The following is a description of a gene set: Hyperphenylalaninemia Human Gene Set: HP_HYPERPHENYLALANINEMIA An increased concentration of L-phenylalanine in the blood. species: Homo sapiens, and this is the list of marker genes: PCBD1, PTS, QDPR, PAH, SPR, GCH1